Given this list of marker genes CYP21A2, here is a description of the gene set: part of: Metabolic disorders of biological oxidation enzymes Steroid 21-hydroxylase (CYP21A2) specifically catalyses the 21-hydroxylation of steroids which is required for the adrenal synthesis of mineralocorticoids and glucocorticoids. Defects in CYP21A2 can cause adrenal hyperplasia 3 (AH3; MIM:201910), a form of congenital adrenal hyperplasia (CAH) where cortisol synthesis is defective. This results in increased ACTH levels, causing overproduction and accumulation of cortisol precursors, particularly 17-hydroxyprogesterone (17HPROG). The resultant excessive production of androgens causes virilization. 21-hydroxylase deficiency accounts for more than 90% of CAH cases and ranges from mild to complete loss of activity. Reactome Pathway: Defective CYP21A2 causes AH3 studied in species Homo sapiens